The following is a description of a gene set: Mouse Gene Set: MIR_3963 Genes predicted to be targets of miRBase v22 microRNA mmu_miR_3963 in miRDB v6.0 with MirTarget v4 prediction scores > 80 (high confidence targets). from publication Chen Y, Wang X (PMID 31504780) species: Mus musculus, and this is the list of marker genes: Pfn2, Klk6, Fat3, Bmf, Eif4enif1, Dst, Cap1, Tex9, Olfml1, Tceal9, Chtf8, Kansl2 (KAT8 regulatory NSL complex subunit 2), Dbndd1, Gabrb2, Saa4, Ak5, Mrps31, Pdlim5, Amz2, Smpd1 (NCBI Gene Id 20597), Nphs2, Cd83, Macir, Cd80, Foxk1, Maml2, Cttn, Lox, Kcnh8, P3h1, Rspo3, Stx4a